Given this list of marker genes TP53, TBX19, GLI3, POU3F4, CTNNB1, POMC, ARNT2, CDH23, MEN1, ZNRF3, CDKN2A, AIP, TERT, LHX3, PRKAR1A, here is a description of the gene set: Adrenocorticotropic hormone deficiency A reduced ability to secrete adrenocorticotropic hormone (ACTH), a hormone that stimulates the adrenal cortex to secrete of glucocorticoids such as cortisol. species: Homo sapiens Human Gene Set: HP_ADRENOCORTICOTROPIC_HORMONE_DEFICIENCY